Given this list of marker genes SV2A, CEP55, SLC7A5, ENO2, PITX1, FZD1, MSX2, HJURP, UBE2S, CENPF, CDH11, TPX2, CCNB1, CCNB2, NCAPH, PCLAF (PCNA clamp associated factor), GTSE1, CDC20, CCN4, LEF1, BUB1, EFNA3, TNC, FGFR3, HMGA2, HMMR, SSX4, KIF20A (NCBI Gene Id 94421), MKI67, NRP2, ROR2, CRABP1, CDK1, CDH3, CCNA2, CENPA, SSX1, PRPH, FOXF2, PLP2, UBE2C, HS3ST3A1, MLLT11, APLP1, COL2A1, MELK, SLC16A3, NEK2, GPSM2, DLGAP5, INHBA, CRLF1, GREM1, WIF1, NUSAP1, RRM2, SSX3, PBK, TOP2A, AHNAK2, SCG5, FGF9, CKS2, CDCA8, CENPE (centromere protein E), SHOX2, CDKN3, MCM4, CENPN, COL9A3, KIF11, TPBG, BIRC5, NCAM1 (neural cell adhesion molecule 1), FOXD1, MAGEA3, SHISAL1, COL11A1, TBL1X, SSX2, GLT8D2, ASPM, FBN2, PSD3 (pleckstrin and Sec7 domain containing 3), NPTX2, KIF2C, MICAL2, TRPS1, ESPL1, here is a description of the gene set: Human Gene Set: NAKAYAMA_SOFT_TISSUE_TUMORS_PCA2_UP In soft tissue sarcomas, the diagnosis of malignant fibrous histiocytoma (MFH) has been a very controversial issue, and MFH is now considered to be reclassified into pleomorphic subtypes of other sarcomas. To characterize MFH genetically, we used an oligonucleotide microarray to analyze gene expression in 105 samples from 10 types of soft tissue tumors. Spindle cell and pleomorphic sarcomas, such as dedifferentiated liposarcoma, myxofibrosarcoma, leiomyosarcoma, malignant peripheral nerve sheath tumor (MPNST), fibrosarcoma and MFH, showed similar gene expression patterns compared to other tumors. Samples from those five sarcoma types could be classified into respective clusters based on gene expression by excluding MFH samples. We calculated distances between MFH samples and other five sarcoma types (dedifferentiated liposarcoma, myxofibrosarcoma, leiomyosarcoma, MPNST and fibrosarcoma) based on differentially expressed genes and evaluated similarities. Three of the 21 MFH samples showed marked similarities to one of the five sarcoma types, which were supported by histological findings. Although most of the remaining 18 MFH samples showed little or no histological resemblance to one of the five sarcoma types, 12 of them showed moderate similarities in terms of gene expression. These results explain the heterogeneity of MFH and show that the majority of MFHs could be reclassified into pleomorphic subtypes of other sarcomas. Taken together, gene expression profiling could be a useful tool to unveil the difference in the underlying molecular backgrounds, which leads to a rational taxonomy and diagnosis of a diverse group of soft tissue sarcomas. Top 100 probe sets contrubuting to the positive side of the 2nd principal component; associated with adipocytic differentiation. species: Homo sapiens from publication Nakayama R, Nemoto T, Takahashi H, Ohta T, Kawai A, Seki K, Yoshida T, Toyama Y, Ichikawa H, Hasegawa T (PMID 17464315)